The following is a description of a gene set: Genes predicted to be targets of miRBase v22 microRNA mmu_miR_504_5p in miRDB v6.0 with MirTarget v4 prediction scores > 80 (high confidence targets). from publication Chen Y, Wang X (PMID 31504780) Mouse Gene Set: MIR_504_5P species: Mus musculus, and this is the list of marker genes: Sik1, Cxxc4, Atoh8, Prrc1, Tent4b, St6galnac6, Fzd7, Chd6, Nrf1, Pla2g2f, Mid1, Cebpz, Foxf2, Plppr5, Arnt, Shank3, Trp53inp1, Inhbc, Ube2g1, Chd3, Rnf114, Il5, Serpina5, Plxna4 (NCBI Gene Id 330281), Pramel34, Mfsd4b3-ps, Rragc, Zbtb49, 2610528J11Rik, Tmem121b, Prrc2b, Crtam, Samd11, Lrrc8a, Zkscan1, Kcna2, Elovl6, Neurl1a, Stx3, Myt1l, Fer1l4, Yes1, Stk24, Mapre2, Ube3c, Pramel47, Ccdc30, Zmynd11, Cacna1e, Arnt2, Clcn7, Mecom, Insyn2a, Fxr2, Creb5, Pcdh17, Hip1, Cnot2, Zfp276